The following is a description of a gene set: While the single nucleotide replacement pathway appears to facilitate the repair of most damaged bases, an alternative BER pathway is evoked when the structure of the 5'-terminal sugar phosphate is such that it cannot be cleaved through the AP lyase activity of DNA polymerase beta (POLB). Under these circumstances, a short stretch of residues containing the abasic site is excised and replaced. Following DNA glycosylase-mediated cleavage of the damaged base, the endonuclease APEX1 is recruited to the site of damage where it cleaves the 5' side of the abasic deoxyribose residue, as in the single nucleotide replacement pathway. However, POLB then synthesizes the first replacement residue without prior cleavage of the 5'-terminal sugar phosphate, hence displacing this entity. Long-patch BER can be completed by continued POLB-mediated DNA strand displacement synthesis in the presence of PARP1 or PARP2, FEN1 and DNA ligase I (LIG1). When the PCNA-containing replication complex is available, as is the case with cells in the S-phase of the cell cycle, DNA strand displacement synthesis is catalyzed by DNA polymerase delta (POLD) or DNA polymerase epsilon (POLE) complexes, in the presence of PCNA, RPA, RFC, APEX1, FEN1 and LIG1. In both POLB-dependent and PCNA-dependent DNA displacement synthesis, the displaced DNA strand containing the abasic sugar phosphate creates a flap structure that is recognized and cleaved by the flap endonuclease FEN1. The replacement residues added by POLB or POLD/POLE are then ligated by the DNA ligase I (LIG1).<br><br> Reactome Pathway: Resolution of AP sites via the multiple-nucleotide patch replacement pathway species: Homo sapiens part of: Resolution of Abasic Sites (AP sites), and this is the list of marker genes: PARP2, RPA3, PARG, PCNA, RFC2, POLE3, RFC1 (replication factor C subunit 1), POLD4, ADPRS, FEN1, POLE, RFC3, PARP1, RPA2, POLD3, LIG1, POLB, POLE2, RFC4 (NCBI Gene Id 5984), RFC5, POLD1, APEX1, POLD2, POLE4, RPA1